The following is a description of a gene set: Human Gene Set: GOBP_NEGATIVE_REGULATION_OF_AUTOPHAGY_OF_MITOCHONDRION Any process that stops, prevents or reduces the frequency, rate or extent of mitochondrion degradation by autophagy. studied in species Homo sapiens, and this is the list of marker genes: TSC2, USP30, TSPO, VPS13C, PPTC7, HTRA2, TIGAR, RBX1, FBXL4, PINK1, RNF41, TP53